The following is a description of a gene set: from publication Chen Y, Wang X (PMID 31504780) Mouse Gene Set: MIR_12201_5P studied in species Mus musculus Genes predicted to be targets of miRBase v22 microRNA mmu_miR_12201_5p in miRDB v6.0 with MirTarget v4 prediction scores > 80 (high confidence targets)., and this is the list of marker genes: Pdlim3, Il1rap, Suox, Gpr22, Cav2, Cnpy3, Ankrd13a, Trpm3, Inka2, Tfap4, Gpr173, Brsk2, Cdkl3, Setd5, Syn3, Mrm2, Rph3a, Atf7, Rp2 (retinitis pigmentosa 2 homolog), Dennd2b (DENN domain containing 2B), Mtf1, Cplx2, Siglecl2, Cldn10, Zfp395, Ascl4 (NCBI Gene Id 67341), Rab6b, Trim41, Pde1a, Ptafr, Ap1s3, Kif11, Efr3b, Lpp, Mecom, Mecp2 (methyl CpG binding protein 2), Txlnb, Kdm5a, Klhl18, Derl3, Rbbp7, Napb, Zfp937, Grm4, Tmem184b, Lhx6, Camkk2, Sfxn4, Commd7, Bard1 (NCBI Gene Id 12021), Mylk4, Rock2 (NCBI Gene Id 77848), Snx12, Acaa2, Atg4c, Trim32, Seh1l, Tlcd5, Scmh1, Rfng, Emp2, Pou2af1, Shisa6, Kansl1, Shisa7, Glyr1, St6galnac3, Hoxb2, Enpp4, Prrx1, Bcl9, Nfat5, Zyx (NCBI Gene Id 97340), Hpgd, Mprip, Insyn2b, St8sia1, Slfn14 (NCBI Gene Id 637877), Plekhh2, Gad1, Gpkow (G patch domain and KOW motifs), Frmpd4, Zmiz2, Ubqln2, Shisa9, Rnf111, Zscan22, Gpr107, Abcf2, Atp2b4 (ATPase, Ca++ transporting, plasma membrane 4), Aebp2, Rab3il1, Zmiz1, Mpped1 (NCBI Gene Id 52878), Psmb11, Ctsk, Mllt11, Slc8a1, Elmo1, Gucy1a2, Naa60, Cd300lg, Nudt3, Rnf2, Heph (NCBI Gene Id 352988), Nudt18 (nudix hydrolase 18), Pik3c2b, Stat3, Hnf1b, Chit1, Tmem138, Btf3l4, Arid2 (AT-rich interaction domain 2), Adissp, Sema6a, Erv3, Camk2d, Zfp213, Tgm3, Cflar, Trim67, Slc6a13, Bmpr2, Rusc1, Snph, Naa20, Nrn1, Cxcl9, Arhgap15, Cpt1a, Casr, Ulk3, Col1a2, Myoz3, Ubap1, Tle1, Rbms3, Gak, Ttpal, Kynu, Mcc, Trpm5, Snap29, Ppp1r18, Fancg, Sgk1, Gpld1, 9330182O14Rik, Hoxb9, Epc1, Traf3ip1, Svs3a, Jph4, Atxn7l3, Nipsnap1, Serpina1a (NCBI Gene Id 544889), Plpp3, Gmeb2, Tmem164, Zfp592, Ccn1, Spock1, Yeats2, Hbp1, Nus1, Ppp1r14c, C5ar1, Marchf5, Rp1, Cntf, Neu3, Cirbp, Grxcr2, Slc16a14, Grik3, Ash1l, Nr5a1, Fam131b, Dhx16 (NCBI Gene Id 69192), Myo5c, Osbp, Aldh1a2, Atrx, Rsad1, Jade2, Rnf150, Aoc1l2, Tet3, Nalf1, Wnk3, Ppp2r2a, Htr2c, Sec62, Mtcl2, Nav1, Zfp771, Trp53, Prkacb, Dusp22, Stat1, B3galt1, Junb (jun B proto-oncogene), Ipo11, Traf1, Sacs, Sema4g, Col14a1, Zbtb39, Stag2, A2ml1, Ambra1, Esrrg, Nck1, Cfap141, Lrrc39 (NCBI Gene Id 77307), Cramp1, Zbtb4, Zkscan8, Mark2, Wnt1, Stra6, Lrrn1, Metap1 (NCBI Gene Id 99872), Dsg1a, Nptx1, Rab35, Cdh8, Zmym4, Nabp2, Tmem33, B4galnt1, Tmem40, St7l, Hsd17b1, Pdk4, Fry, Plscr3, Hoxa1, Ociad1 (OCIA domain containing 1), Arl5a, Pfkfb3 (6-phosphofructo-2-kinase/fructose-2,6-biphosphatase 3), Abcb6, Cdk12, Aqp7, Gstm7, Dstyk, Ark2n (arkadia (RNF111) N-terminal like PKA signaling regulator 2N), Cbx7, Ttc3, Cd274, Syt14, 7530416G11Rik, Mrgprb1 (MAS-related GPR, member B1), Zfp26, Gid4, Trmt10a, Jam3, Zbtb16, Gng2, Rab15, AI987944, Slamf7, Pphln1, Elfn2, Gba2, Prickle1, Gnb1l, Aasdhppt, Egr3, Col3a1, Slc35d1, Spop, Orc5, Myh11, Ada, Btbd16, Rpa1, Picalm, Zbtb21, Grap2, Eya3, Fam163b, Ss18 (SS18, subunit of BAF chromatin remodeling complex), Nfasc, Otc, Matcap1 (microtubule associated tyrosine carboxypeptidase 1), AW146154, Prr23a4, Ap1s1, Aak1